Given this list of marker genes JAGN1, FOSL2, FAM3C, EVI2B, TRIB1, LBR, LEF1, INPP5D, FASN, CSF2, BAP1, here is a description of the gene set: studied in species Homo sapiens The process in which a myeloid precursor cell acquires the specialized features of a neutrophil. Human Gene Set: GOBP_NEUTROPHIL_DIFFERENTIATION